Given this list of marker genes Pttg1, Fmn2, Terf1, Cenpc1, Ccne2, Msh4, Stag3, BC005624, Spata22, Haspin, Tex11, Prdm9, Mlh1, Majin, 4930447C04Rik, Ube2b, Ago4, Shoc1 (shortage in chiasmata 1), Spo11, Rnf212b, Cpeb1, Zwint, Meiob, Meioc, Terb2 (NCBI Gene Id 74401), Brip1, Terb1, Tex15, Ccne1, Dmc1, Ndc1, Mre11a, Rad21l, Mael, Spdya, Mcmdc2, Bend2, Tex19.1, Mei4, Msh5, Syce3, Sycp1, Tex12, Kash5, Syce1l, Fancd2, Rnf212, Mei1, Mnd1, Syce2, Sirt7, Brca2, Bag6, Rec8, Knl1, Mlh3, Ccnb1ip1, Plk1, Trip13, Meikin, Hormad1, Sycp3, Iho1, Atm, Sun1, Psmc3ip, Syce1, Ankrd31, 1700028K03Rik, Cep63, Zcwpw1, Ehmt2, Syde1, Morc2b, Espl1 (extra spindle pole bodies 1, separase), here is a description of the gene set: The cell cycle process in which replicated homologous chromosomes are organized and then physically separated and apportioned to two sets during the first division of the meiotic cell cycle. Each replicated chromosome, composed of two sister chromatids, aligns at the cell equator, paired with its homologous partner; this pairing off, referred to as synapsis, permits genetic recombination. One homolog (both sister chromatids) of each morphologic type goes into each of the resulting chromosome sets. Mouse Gene Set: GOBP_HOMOLOGOUS_CHROMOSOME_SEGREGATION species: Mus musculus